The following is a description of a gene set: Mouse Gene Set: GOBP_LENS_MORPHOGENESIS_IN_CAMERA_TYPE_EYE studied in species Mus musculus The process in which the anatomical structures of the lens are generated and organized. The lens is a transparent structure in the eye through which light is focused onto the retina. An example of this process is found in Mus musculus., and this is the list of marker genes: Bmp4, Ctnnb1, Lctl (lactase-like), Tdrd7, Epha2, Sox1, Nectin3, Abi2, Fgfr3 (fibroblast growth factor receptor 3), Pou2f1, Ski, Shroom2, Prox1, Cited2, Meis1, Cryaa, Tbc1d20, Six3 (sine oculis-related homeobox 3), Atf4, Crygb, Hipk2, Sox11, Bcar3, Hipk1, Pitx3, Nectin1, Sox2, Tfap2a